Given this list of marker genes INPP1, RDH12, SEMA3E, CDC6, TSPAN2 (NCBI Gene Id 10100), TSTD1, LTC4S, HAAO, ITPRIPL2, DNAH7, KATNBL1, ITGB5, SH3PXD2A, AGO4, IRAK3, KCNE3, MLLT6, USP18, TNFSF9, PSENEN, CMTM3, HLA-DMA, IL1A, SUSD6, ZNF524, PARD3B, HLA-E, NCF4, CACNA1D (NCBI Gene Id 776), CTSD, S1PR3, SMARCA4, RUNX2, SDC2, KPNA4, ATP13A3, CD37, HOATZ, ARL6, IL13, ERN1, FAM222B, RASSF10, ELL2, POU6F1, ST8SIA1, MAOA, PTPN3, IFI27, PYCARD, SOX4, FAM174C, SOCS2, DAPK2, GSDME, ZBED5, PRMT2, PLEKHA2 (NCBI Gene Id 651347), FRZB, PHF13, KRT10, MAPK11, BMPER, GRAMD1C, INPP5K, GSTT2, LZIC, ZWINT, FAM111A, IFT25, GPR183, SH3BP5, ECE1, RAB31, BLM, SH2D1B, GPR107 (G protein-coupled receptor 107), MMAA (metabolism of cobalamin associated A), DDX60, DLGAP4, RELN, CYRIA, GPX4, PTGIR, DUSP12, IGIP, CTSS, ICOS, ARHGAP26, TLR1, GATA3, KCTD15, IL18, XAF1, JUP, TANK, PLEKHO1, NOTCH1, LFNG, LRRC1, STXBP6, HMGN3, TNS2, ELMO3, KCNA3, TBX6 (NCBI Gene Id 6911), SPIC, ITGA4, SLC43A3, NAPSA, IL10RB, LGALS3BP, AIP, TRAF3IP3, RO60, IPO4 (NCBI Gene Id 79711), CNN2, LSP1, MOV10, ZNF141, SELENOM, GLIPR1, PPFIBP2, ARHGEF25, MCF2L, DISP1, GPX7, CDKN2B, FAH, GBA2, CENPJ, CCDC66, LAYN, VEGFC, GRK3, RAB5B (RAB5B, member RAS oncogene family), ZNF689, PLCB4, MAP4, CAMK2N1 (calcium/calmodulin dependent protein kinase II inhibitor 1), HS3ST3A1, CD52, PARP12, CYB561A3, BMP4 (NCBI Gene Id 652), RCN2, AGA, TMCC3, GNA14, ARAP2, RTN4IP1, GNGT2, SLCO2B1, PIK3R5, CHRNB1, C1orf54, MS4A7, HPN, ADAMTS20, MGAT4A, PIR (NCBI Gene Id 8544), PSME2, ABHD6 (abhydrolase domain containing 6, acylglycerol lipase), NCBP2, TMBIM4, MYLIP, LIG4 (NCBI Gene Id 3981), LXN, GBP2, CD48, IGDCC4, ACP5, IFNAR1, SETD4, SLAMF9, SPIRE2, FGD4, GSAP, KRIT1, CLNK, GBP7, EVA1B (eva-1 homolog B), FASTKD3, OSBPL3, ZNF229, BST2, RIMS3, ASAH2, SGPL1, EHD1 (EH domain containing 1), MRPL52, SKAP2, TMEM35B, TEP1, LRATD2, HRH1, SLFN13, SIL1, FLNB, IRF4, here is a description of the gene set: from publication Lind EF, Ahonen CL, Wasiuk A, Kosaka Y, Becher B, Bennett KA, Noelle RJ (PMID 18566401) Genes down-regulated in dendritic cell wildtype LPS and anti-CD40 stimulated versus dendritic cell NIK NFkB2-KO LPS and anti-CD40 stimulated. This study aims at identifying genes that are NIK/NF-kappaB2 responsive in murine dendritic cells matured in vivo. Human Gene Set: GSE7219_WT_VS_NIK_NFKB2_KO_LPS_AND_ANTI_CD40_STIM_DC_DN species: Homo sapiens